The following is a description of a gene set: A series of intracellular molecular signals mediated by TORC1; TOR (target of rapamycin) in complex with at least Raptor (regulatory-associated protein of TOR), or orthologs of, and other signaling components. Human Gene Set: GOBP_TORC1_SIGNALING species: Homo sapiens, and this is the list of marker genes: SEC13, FNIP2, UBE2N, MTOR, VHL, RNF152, NPRL2, ITFG2, CUL3, FLCN, SYK, RPS6KA3, WDR59, RBX1, UBE2D1, SMCR8, NPC1, ATXN3, SAR1B, MAT2A, CASTOR3P, PPDPF, RRAGD, YWHAZ, PRKACB, AKT1S1, LAMTOR5, WDR24, RPS6KB2, MAPK3, USP7, RPS6KB1, RPS6KA4, CSNK1A1, RPTOR, SPAAR, RRAGA, LAMTOR1, PIM1, SAMTOR, TBC1D7, CASTOR1, RRAGB, RHEB, PRKAA2, GPR137B (G protein-coupled receptor 137B), PIP4P1, EP300, SZT2, UBE3A, STK11, PELI1, SRC, LARP1, LAMTOR3, ATXN3L (ataxin 3 like), STAMBPL1, CASTOR2, DGKQ, CARD11, OTUB1, AKT1, RPS6KA6, SEH1L, SRMS, KLHL22, WAC, SLC38A9, KICS2, OTUD7B, TBK1, RPS6KA1 (NCBI Gene Id 6195), NPRL3, DEPTOR, C9orf72, KPTN, DEPDC5, PRKAA1, SESN2, RRAGC, PRMT1 (protein arginine methyltransferase 1), LAMTOR2, GPR137, MIOS, USP32, CLEC16A, GPR155, UBE2W, PIH1D1, SHQ1, USP4, SESN1, SAR1A, TSC1, OGT, YWHAG, NLK, TSC2, SESN3, PRKACA, GPR137C, CTNS, MFSD8 (NCBI Gene Id 256471), RPS6KA5, FNIP1, ATM, LAMTOR4, OTUD5, MLST8, DYRK3, SIK3, RPS6KA2, RNF167, LARS1